Given this list of marker genes Tmem237, Slc24a4, Rd3, Pcare, Guca1b, Opn1sw, Ift140 (intraflagellar transport 140), Prkca, Cnga3, Guca1a, here is a description of the gene set: studied in species Mus musculus Mouse Gene Set: GOCC_CONE_PHOTORECEPTOR_OUTER_SEGMENT The outer segment of a vertebrate cone photoreceptor that contains membrane discs that are contiguous with the ciliary membrane and containing opsin photoreceptor proteins.